Given this list of marker genes NVL, MPHOSPH6, EXOSC7, EXOSC9, GTPBP1, EXOSC10, EXOSC1, CARHSP1, MTREX, EXOSC8, EXOSC3, ZFP36, EXOSC5, EXOSC2, WDR74, EXOSC6, EXOSC4, ZFC3H1, DIS3, KHSRP, C1D, DIS3L, here is a description of the gene set: Human Gene Set: GOCC_EXOSOME_RNASE_COMPLEX A ribonuclease complex that has 3-prime to 5-prime exoribonuclease activity and possibly endoribonuclease activity, producing 5-prime-phosphomonoesters. Participates in a multitude of cellular RNA processing and degradation events preventing nuclear export and/or translation of aberrant RNAs. Restricted to processing linear and circular single-stranded RNAs (ssRNA) only. RNAs with complex secondary structures may have to be unwound or pre-processed by co-factors prior to entering the complex, esp if the 3-prime end is structured. studied in species Homo sapiens